Given this list of marker genes Ptk2, Moap1, Kdr, ENSMUSG00000144291, Tsc2, Cdk16, Parl, Yod1, Tcirg1, Pafah1b2, Spata18, Mapt, Rab1b, Pikfyve, Tm9sf1, Trim23, Tmem41b, Scoc, Arl8b, Elapor1 (NCBI Gene Id 99950), Rab33a, Gabarapl2, Sptlc1, Ufm1, Col6a1, Arsb, Irgq (immunity-related GTPase family, Q), Rnf152, Vps41 (VPS41 HOPS complex subunit), Nipsnap2, Zdhhc19, Znrf1, Rubcn, Znrf2, Abi2 (abl interactor 2), Drd2, Vps13a, Atg12, Tspo, Scfd1, Gopc, Zfyve1, Tfeb, Tbk1, Cd84, Stk11, Fis1, Ap5z1, Pik3c2b, Pik3c2a, Dnm1l, Klhl22, Itgb4, Gimap6, Mtcl2, Bok, Adcy10, Irgm2, Map1lc3b, Slc25a46, Ikbkg, Foxo1, Sting1, Epg5, Pim2, Mtm1, Golga2, Ptpn22, Rock1, Tmbim6, Mcl1, Huwe1, Wac, Mul1, Arfip2, Htra2, Calm2, Ambra1, Trim32, Ddrgk1, Erfe, Akt1, Rubcnl, Rragc, Xbp1, Aup1, Tbc1d12, Ubqln4, BC004004, Fyco1, Cttn (NCBI Gene Id 68623), Mtmr9, Vps16, Rragd, Fez1, Dcaf12, Plaa, Irf8, Vps39, Tex264, Atg9a, Wdr24, Tbc1d25, Il10ra, Csnk2a1 (casein kinase 2, alpha 1 polypeptide), Hif1a, Tigar, Mapk15, Trappc4, Lyn (NCBI Gene Id 99963), Stbd1, Sptlc2, Phf23, Sh3glb1, Acbd5, Xpa (NCBI Gene Id 22590), Elp6, Dap, Pjvk (NCBI Gene Id 381375), Usp30, Cisd2, Nrbf2, Dram2, Snx7, Zfyve26, Clec16a, Bmf, Eva1a, S100a8 (NCBI Gene Id 99591), Pptc7, Ehmt2, Calm3, Timm23, Plk3, Hmgb1, Atg16l2, Fez2, Tbc1d14, Gabarapl1, Smcr8, Atg4a (autophagy related 4A, cysteine peptidase), Gsk3b (NCBI Gene Id 98033), Ift20, Fundc2, Tom1, Fnbp1l, Ei24, Usp20, Mapk3, Usp10, Chek2, Mtcl3, Rufy4, Pik3r4, Sqstm1, Il10, Flcn, Gm12185, Atg4c, Usp33, Chmp6 (NCBI Gene Id 69715), Vti1b, Gabarap (gamma-aminobutyric acid receptor associated protein), Vdac1 (NCBI Gene Id 22333), Gpsm1, Map3k7, Pip4k2b (phosphatidylinositol-5-phosphate 4-kinase, type II, beta), Cers1, Atg7, Traf6, Sirt2, Fbxl4, Pik3c3, Retreg1, Gpr137b, Atg2a, Qsox1, Trim65, Atp5if1, Bcl2, Gm5431, Ddit3, Vmp1, Trim8, Map2k1, Rab39, Igtp, Atp6v0a1, Gm4841, Rab33b, Trp53, Smo, Rab1a, Ubxn2a, Optn, Nbr1, Wdfy3 (WD repeat and FYVE domain containing 3), Nprl3, Depp1 (DEPP1 autophagy regulator), Atg101, Cltc, Trp53inp2, Dapl1, Slc35d3, Iigp1c, Atg9b, Sesn1, Mtor, Nod1, Lep, Umod, Rnf186, Tmem208, Ercc4, Clu (NCBI Gene Id 28201), Trim30b, Prkd1, Hdac6, Ep300, Ogt (O-linked N-acetylglucosamine (GlcNAc) transferase (UDP-N-acetylglucosamine:polypeptide-N-acetylglucosaminyl transferase)), Ifng, Hap1, Vps51, Rmc1, Rragb, Slc7a5, Deptor, Anxa7, F830016B08Rik, Pex2, Phb2, Ifnb1, Gramd1a, Calm1, Snca, Vcp, Prkaa1, Vps13d, Tecpr1, Gaa, Eif4g2, Nipsnap1, Adrb2, Afg2b, Gata4 (GATA binding protein 4), Mfsd8, Lrpprc, Stx17, Zmpste24, Ccny (NCBI Gene Id 75537), Dapk1, Lamp2 (lysosomal-associated membrane protein 2), Tmem59, Atg2b, Mtdh, Sirt1, Lmx1b, Tbc1d5, Psen1, Rab12, Vps4b, Bcas3, Wdr45b, Trp53inp1, Sh3bp4, Snx18, Creg1, Svip (NCBI Gene Id 75744), Ubqln1, Rab19, Mid2, Myo5a, Arhgap26, Gsk3a (NCBI Gene Id 76828), Eif2ak1, Irgm1, Lix1l, Tmem150b, Sbf2, Stat3, Nlrp6 (NLR family, pyrin domain containing 6), Trim21, Vps13c, Dnajc16, Rab43, Bag3, Trim13, Bnip3l, Gnai3, Wdr6, Fbxl2, Atg14, Plk2, Chuk, Nupr1, Atm, Tpcn1, Kat8, Gba1, Pip4k2a, Spg11, Ubqln2, Tgtp1, Eif2s1, Zc3h12a, Sesn3, Hk2, Bcl2l11, Rnf31, Lrba, Vps4a, Pik3cb, Atg4d, Nprl2 (NPR2 like, GATOR1 complex subunit), Becn1, Rnf166, Tgtp2, Dele1, Atg10, Ikbkb (NCBI Gene Id 16150), Rab2b, Prkaa2, Ulk3, Snapin, Adra1a, Snf8, Rab3gap1 (NCBI Gene Id 69346), Tnfaip3, Rab23, Chmp1b, Elavl1 (ELAV like RNA binding protein 1), Nampt, Vps33a, Pmp22, Chmp2b, Snx30, Mapk8, Foxk2, Chmp4b, Pycard, Ift88, Retreg2, Ufc1, Retreg3, Rab39b, Zfp418, Atp13a2, Plekhm2, Ifi47, Spart, Vps11, Rab7, Rab2a, Nhlrc1, Rimoc1, Trib3, Ubr4, Casp1, Tafazzin, Mfn2, Herc1, Tpcn2, Lzts1, Atg5, Snap29, Hmox1, Chmp4c, Bid, Hmga1, Cisd1, Atg3, Usp36, Abl1, Atp2a2, Nipsnap3b, Trim30d, Ephb2, Tmem74, 9930111J21Rik1, Wdr45, Rb1cc1, Fundc1, Vti1a, Il4, Ubxn6, Tlr9, Itgb1, Wipi1, Pik3r2, Sesn2 (NCBI Gene Id 230784), Tbc1d17 (TBC1 domain family, member 17), Cdk5rap3, Fkbp8, Stx12, Chmp5, Mtcl1, Slc25a5, Cryba1, Wdr47, Trim30c, Spata33, Poldip2, Atg4b, Ulk1, Kdm4a, Trim17, Stk38l, Srpx, Cptp, Wnk1, Fbxo7, Fbxw7, Rptor, Fn1, Inhba, Synpo2, Lgals8, Itga5, Srebf1, Tollip, Atf6, Eif4g1, Trim12c, Lrsam1, Vps18, Il3, Ager, Ralb (v-ral simian leukemia viral oncogene B), Atg4a-ps, Ubxn2b, Dram1, Arsa, Pip4k2c, Acvr2a, Pex5, S100a9, Kat5, Fundc2b, Gm12250, Epm2a, Map1lc3a, Rab3gap2, Smurf1, Rraga, Keap1, Pacs2, Ufl1, Ctsa, Dcn, Mlst8, Rasip1, C9orf72, Nrbp2, Tgfbrap1, Atg16l1, Supt5, Bcl2l13, Chmp7, Usp13 (NCBI Gene Id 99731), Washc1, Npc1, Armc3, Ripk2, Foxo3, Plekhf1, Tsc1, Tmem39a, Nod2, Sec22b, Ube2a, Naglu, Zkscan3, Acer2, Prkn, Chmp1a, Ticam1, Nsfl1c, Foxk1, Syt11, Tlr2, Chmp2a, Ormdl3, Mefv, Uvrag, Tomm7, Pink1, Hspb8, 1600014C10Rik, Rab8a, Stub1, Endog, Bnip3, Rnf41, Hspa8, Efnb1, Wdr81, Calcoco2, Htt, Trim27, Plekhm1, Iigp1, Rab24, Emc6, Lix1, Wdfy4, Cdkn2a, Wipi2, Ulk2, Gpr137, Trim5, Cdc37, Becn2, Trim30a, Trim12a, Snx4, Mcoln1, Uba5, Vamp8, Drd3, Bmal1, Wdr41, Rnf5, Snx14, Lypla1 (lysophospholipase 1), Setd2, Trem2, Depdc5, Atg13, Lepr, Chmp1b2, Chmp3, Diaph3 (diaphanous related formin 3), Hdac10, Ap4m1, Pdcd6ip, Larp1, Cln3, Mtmr3, Lrrk2, Rnf185, Slc25a4, Lamp3, Dnm2, Gfap, Ctsd, Ilrun, Rnf213, Park7, here is a description of the gene set: Mouse Gene Set: GOBP_PROCESS_UTILIZING_AUTOPHAGIC_MECHANISM species: Mus musculus A cellular process involving delivery of a portion of the cytoplasm to lysosomes or to the plant or fungal vacuole that does not involve direct transport through the endocytic or vacuolar protein sorting (Vps) pathways. This process typically leads to degradation of the cargo; however, it can also be used to deliver resident proteins, such as in the cytoplasm-to-vacuole targeting (Cvt) pathway.